Given this list of marker genes KLF4, SCYL2, NLE1, EDN1, CCN4, NPHP3, WLS (NCBI Gene Id 79971), SFRP5, VGLL4, ADGRA2, LDB1, SOX30, TCF7L2 (NCBI Gene Id 6934), CTNNB1, RNF213, MIR145, NOG, GREM1, PRKN, EDNRA, LRRK2, VAX2, HIC1, NFATC4, VANGL1, DEPDC1B, RAC1, NHERF1, WWOX, TBX18, LRP6, CCDC134, TSKU, LRP1, DVL2, FZD5, DKKL1, HNF1B, FRMD8, COL1A1, RBX1 (NCBI Gene Id 9978), CTNNBIP1, CRBN, PLCG2, SHISA2, CSNK1E, FZD3, TMEM9, COL6A1, CPE, KANK1, MIR212, CELSR2, UBE2B, WWTR1, RNF146, STK11, NPHP4 (NCBI Gene Id 261734), SOX9, GSK3B, PRKAA1, LATS1 (large tumor suppressor kinase 1), FBXW4, SENP2, LIMD1, RSPO3, TNFAIP3, WNT10B, ETV2, WNK1, FZD8 (frizzled class receptor 8), CYLD, EDNRB, SOX4, DRAXIN, CCNE1, CDH2, DAAM2, TMEM131L, FRAT2, ATP6AP2, KPNA1, NR4A2, TIAM1, CMAHP, SHISA6, TMEM64, BCL9L, ZBTB33, LEO1, SMARCA4, LGR5, SHISA3, NOTUM, EPM2A, ARL6, HMGXB4, TCF7, GSC, IGFBP6, STRN (NCBI Gene Id 6801), DLX5, FBXW11, ROR1, USP8, LBX2, DDX3X, GLI3, LATS2, HHEX, DKK1, NFKB1, INVS, GPRC5B, WNT1, SOX17, SBNO1, KLF15, FZD2, PKD1, RSPO4, TMEM170B, WNT16, TLR2, MYOC, RACK1, RNF43, XIAP, CDK14, FRAT1, DKK3, ABL1, FGFR2, MAD2L2, WNT3A, CPZ, DKK4, HMGA2, LRP5, WNK2, GSKIP, SIAH1, DAPK3, BMP2 (bone morphogenetic protein 2), BIRC8, RHOA, FGF9, CUL3, CITED1, MED12, FOXO1, DLX3, AMER1, JRK, IFT20, RARG, ROR2, MCC, PAF1, WNT11, AXIN1, DRD2, HESX1, PPM1N, CSNK1G3, TLE7, GATA3, RUVBL2, ANKRD6, PRKAA2, VPS4B, CSNK1A1, TLE3, CELSR1, AMFR, PORCN, WNT8A, SCEL, DISC1, MIR498, SALL1, CTHRC1, UBR5, TRABD2B, PPM1A, NXN, PITX2, GRB10, MIR203A, MESP1 (mesoderm posterior bHLH transcription factor 1), IFT80, CDC42, CTDNEP1, WNT7A, CELSR3, PIN1, APOE, GLI1, MIR29C, MIR29B1, EMD, FGF10, USP34, GRK6, PTPRO, WNT10A, EXT1, LYPD6, CSNK1G1, BBIP1, NKX2-5, FGF2, RAC3, MIR1-1, HDAC1, MACF1, MBD2, WNT6, RNF138, NDRG2, VANGL2, WNT5A, FOLR1, RNF14, EGFR, FZD10, IGFBP4, WNT7B, WNT9B, DCDC2, FZD9, PYGO1, SFRP2, RYK, RAB5A, TERT, LRRK1, KLHL12, TMEM88B, FZD4, AMER3, STK4, EGF, RBPJ, SULF1, RPS12, POU5F1, DVL1, TLE6, IGFBP2, SPIN4, WNT4, CTNND2, GRK5, OTUD5, SPIN1, LZTS2, CTNND1, SDHAF2 (succinate dehydrogenase complex assembly factor 2), AMOTL1, TNIK, SFRP1, GPC4, BCL7B, APC2, APCDD1L, GNAQ, BBS4, PLPP3, TGFB1I1, DACT1, PRICKLE2, JADE1, WNT2B, RUVBL1, APP, SULF2, PIAS4, TPBG, DKK2, BAMBI, CSNK1D, SEMA5A, MARK1, WNT2, TLE5, TRPM4, BARX1, CCNYL1B, LRRFIP2, RSPO1, CELA1, LEF1 (NCBI Gene Id 51176), SMURF1, MIR501, MITF, SMAD4, RBMS3, GPC5, RTF1, MIR199A1, MIR183, MIR1260B, ASPM, CAPRIN2, DIXDC1, SOST, TLE2, PPP2R3A, SKI, NDP, APCDD1, DAB2IP, MIR224, SHH, GSK3A, ZEB2, TMEM132A, CCAR2, BICC1, TMEM88, VPS35, PYGO2, ALPK2, ITGA3, TNKS, ZNRF3, HECW1, MIR32, TMEM237 (transmembrane protein 237), MDFIC2, PBXIP1, SNAI2, FERMT2, TLE4, FUZ (fuzzy planar cell polarity protein), WNT3, NKD1, MYC, CTR9, MIR26A1, CDH3, SDC1, BRD7, PTPRU, C12orf43, CXXC4, TMEM67, FRZB, FOXD1, CSNK2A1, SFRP4, PCDH11Y, PLEKHA4, CCND1, MIR19B1, IFRD2 (interferon related developmental regulator 2), CCNY, MKS1, YAP1, FAM53B, WNT5B, AXIN2, CSNK2A2, PFDN5, SRC, CSNK2B, DAB2, ZRANB1, CHD8, WNT9A, SMAD7, LMBR1L, GID8, SOX2 (NCBI Gene Id 6657), CCNYL1, ISL1, TPBGL, CD24, ZNF703, TNKS2, SOX13, STK3, DVL3, FZD7, CCDC88C, JUP, TMEM196 (NCBI Gene Id 256130), APC, MAPK14, DACT3, SMAD3, HBP1, KREMEN1, TGFB1, CALCOCO1, DDIT3, OTULIN, DAAM1, GPC3 (glypican 3), CDC73, UBAC2, MLLT3, SOX10, RNF220, AMOTL2, MDK, SNX3, LGR4, PRDM15, SOSTDC1, TLE1, PSEN1, CCNYL2, BTRC, PTK7, TSC2, ADNP, TBL1XR1, MDFIC, CCNYL3, MESD (NCBI Gene Id 23184), AMER2, KREMEN2, SIX3, NPPA, EGR1, SNAI1, SKIC8, MDFI, NRARP, FZD1, NKD2, HSP90B1, CBY1, EDA, CSNK1G2, TBL1X, BMAL1, VCP, PPP2CA, TAX1BP3, USP47, BCL9, ATP6V1C2, MIR665, SPEF1, WNT8B, FERMT1, DDB1, ARHGEF19, ILK, TTC21B, G3BP1, NLK, TCF7L1, CAV1, WIF1 (NCBI Gene Id 11197), LGR6, MIR346, MARK2, FZD6, FRMD8P1, PKD2, RECK, TRABD2A, CSNK1A1L, SIAH2, PPM1B, PRICKLE1, CER1, TMEM198, ZBED3, FOXO3, MAGI2, NOTCH1, LRP4, FOXL1, SMURF2, IFRD1, ATP6V0C, IGFBP1, RSPO2, PPP1CA, here is a description of the gene set: The series of molecular signals initiated by binding of a Wnt protein to a frizzled family receptor on the surface of a target cell and ending with a change in cell state. Human Gene Set: GOBP_WNT_SIGNALING_PATHWAY species: Homo sapiens